The following is a description of a gene set: part of: GABA receptor activation Reactome Pathway: GABA B receptor activation species: Homo sapiens Functional GABA B receptors are heteromers of GABA B1 and B2 subunits, complexed with G protein alpha-i, 0, beta, and gamma subunits. They function as metabotropic receptors. When GABA is bound to the B1 sub-unit, the B2 subunit undergoes a conformational change that releases the G alpha-i G0 dimer (which binds and inactivates cytosolic adenylate cyclase) and the G beta G gamma dimer (which activates the GIRK (KIR3) potassium channel)., and this is the list of marker genes: KCNJ15 (potassium inwardly rectifying channel subfamily J member 15), GNG5, ADCY1, GNAI2, GNAI1, GNAL, KCNJ9, GNB2, GNB1, GABBR2, GNGT1, GNGT2, GNG12, KCNJ3, GNG7, ADCY9, KCNJ12, GNG8, KCNJ5, KCNJ6 (NCBI Gene Id 8206), ADCY6, ADCY8, GNG10, GNG4, GNB4, KCNJ16, KCNJ10, ADCY7, GNB5, GNB3, ADCY3, GNAT3, KCNJ4, GABBR1, KCNJ2, GNG2, GNG11, ADCY5, GNG3, ADCY4, GNAI3, GNG13, ADCY2 (adenylate cyclase 2)